The following is a description of a gene set: Genes down-regulated in CD8 T cells treated by interferon alpha: naïve versus day 8 after LCMV infection. studied in species Homo sapiens Type 1 IFNs can conditionally activate all of the signal transducers and activators of transcription molecules (STATs), including STAT4. The best-characterized signaling pathways use STAT1, however, and type 1 IFN inhibition of cell proliferation is STAT1 dependent. We report that type 1 IFNs can basally stimulate STAT1- and STAT4- dependent effects in CD8 T cells, but that CD8 T cells responding to infections of mice with lymphocytic choriomenigitis virus have elevated STAT4 and lower STAT1 expression with significant consequences for modifying the effects of type 1 IFN exposure. The phenotype was associated with preferential type 1 IFN activation of STAT4 as compared to STAT1. Stimulation through the TCR induced elevated STAT4 expression, and STAT4 was required for peak expansion of antigen-specific CD8 T cells, low STAT1 levels, and resistance to type 1 IFN-mediated inhibition of proliferation. Thus, a mechanism is discovered for regulating the consequences of type 1 IFN exposure in CD8 T cells, with STAT4 acting as a key molecule in driving optimal antigen-specific responses and overcoming STAT1-dependent inhibition of proliferation. Human Gene Set: GSE40666_NAIVE_VS_EFFECTOR_CD8_TCELL_WITH_IFNA_STIM_90MIN_DN from publication Gil MP, Ploquin MJ, Watford WT, Lee SH, Kim K, Wang X, Kanno Y, O'Shea JJ, Biron CA (PMID 22968462), and this is the list of marker genes: EMILIN1, FIZ1, GEMIN8, CACNG4, HNRNPAB, TUBB2B, PLGRKT, MGAT4B, WBP1, PCOLCE, SMIM3, KDM6B, SRSF9, RAD51, RMND5A, MYB, SPATA13, PTGIR, DNAJC18, NSUN4, ISG20, SMOX, BZW2, CD247 (CD247 molecule), DNTT (DNA nucleotidylexotransferase), ZNF740, MFSD10, HACD3, CUX1, FLOT1, MIGA1, PHACTR4, E2F3, PARD6G, PPM1F (NCBI Gene Id 9647), HNRNPH1, ZMYM4, MGRN1, N4BP3, IFT122, SLC16A10, SSBP4, LMNB2, ART5, HMG20A (NCBI Gene Id 55736), UBE2E3, AFDN, ZNF629, TOX, JAZF1, SPSB1, GREB1, IFT57, GART (NCBI Gene Id 2618), ARID1A, MAP2K5, PGGHG, HPF1, ARHGAP20, DNAJB6, CKB, EZH2, ABI3, RNF149, TAX1BP3, ALDH7A1, SREK1IP1, XYLT2, SPEF2, EGR1, DGCR2, NDC1, PRKRA, UBALD2, CUEDC2, SSR1, CKS1B (NCBI Gene Id 88475), CSRP1, TGFB1, PPA1 (NCBI Gene Id 5464), KIFC3, RTP4, IRF4, ARMCX1, KIF3A, CHPT1, ALYREF, ENDOU, EXT1, GNB4, SYCE2, EDARADD, DDX19A, NIBAN3, CHST2, PSMD3, SLC2A9, SYTL2, ANKS1A, CTPS1, PFKM, CCDC88A, TGIF2, MCM5 (minichromosome maintenance complex component 5), ENG, HOMER1, EGR2, HLA-DOA, LDHB, BAZ2B, TSPOAP1, SAMHD1 (SAM and HD domain containing deoxynucleoside triphosphate triphosphohydrolase 1), ENO2, CEP78, GPRASP3, LCMT1, AIFM1, DHX57, FIRRE, IPO11, TANC2, LZIC, CENPS, MCM7, ZNF839, SREK1, RMDN1, DCLRE1A, CTC1, PACSIN1, LHFPL6, SLC16A6, ZNF207, PLA2G4F, SLAMF1, PPP1R16B, MSH6 (mutS homolog 6), ARID2, F13A1, PCDHGC4 (protocadherin gamma subfamily C, 4), EMID1, MRPS6, MTX2, ENO1, TLE3, MMP9, AKR1C3, ITIH5, POP1, TET1, TCP1, EIF1AY, S100PBP, ZC4H2, GNG12, UBE2R2, CSNK1A1, KLHDC8B, CTSV, BCL2L1, GATA3, ILF3, NCOA5, AS3MT, SNHG3, TWSG1, RTN3, STAU2, STK26, N4BP2, CD81, APTX, CENPJ, HNRNPLL, BEX3, CAMKK2, HSPA13, YPEL2, ADGRL1, LCP2, PLOD2, PIK3R3, ITGA8, SLC12A5, SLC39A14, PEBP1, NT5C2 (NCBI Gene Id 22978), CHEK1, BEX1, RBMXL1, UBE2N, KRBA1, ACOT7, PLA2G12A, BRCA2, HEMK1, DAB2IP, SGTA, RALGPS2, NCOA7